The following is a description of a gene set: studied in species Homo sapiens The directed movement of an acylglycerol into, out of or within a cell, or between cells, by means of some agent such as a transporter or pore. An acylglycerol is any mono-, di- or triester of glycerol with (one or more) fatty acids. Human Gene Set: GOBP_ACYLGLYCEROL_TRANSPORT, and this is the list of marker genes: CETP, LPCAT3, CD36, APOH, DENND5B, MIR30C1, MTTP, PRAP1